Given this list of marker genes HPCAL4, TAGAP, DUSP1 (dual specificity phosphatase 1), PEAK1, PAQR5, SORT1, SPEN, RSL24D1, EEF1E1, RYBP, WLS, SBF2, ROGDI, DRG2, BLTP3B, CD68, RRP1B, FNIP1, SERTAD1, HEATR1, ATP23, POLR1B, DNMT3B, KPNA1, MIR543, SCMH1, POLR3E, CPNE4, UTP25 (UTP25 small subunit processome component), KCNF1, TLR7, PTGS2, IFT80, SLC25A29, TIMM10, SLC37A1, CRY2, IL9 (NCBI Gene Id 3578), NR4A2, SLC2A1, THEMIS2, TRPC6, BOLA1, ARHGEF10, SET, ATG4C, CLIC4, VPS33B, TNFRSF18, CD6, CAGE1, PFKL, GBP6, LYN, PAX6 (NCBI Gene Id 5080), CNKSR3, FOXP1, CD274, FXR2, IMPDH1, NUDC, GPATCH4, GRPEL2, GRK3, RAB38, GEMIN5 (NCBI Gene Id 25929), IPO4, GRPEL1, NMD3, AMER1, HYOU1, SLC25A22, HSF1, C1orf35, RBIS, A1CF, RSPRY1, EIF5B, GTPBP6, TRIO, TMEM39A, CZIB, SND1, BLNK, DOCK4, ZC3HC1, UTP20, MRTO4, IARS1, IPCEF1, FLVCR1, LILRB3, NSMCE1, CEACAM1, MTRES1, ISG20L2, CDKN1A, XPO7, CSTF1, MIR376C, TRIM42, TRIM69, SOCS5, MGA, EIF1, KANSL2, KDM5B, NHP2, MRPL38, CXXC1, SMIM12, PPAN, AXIN1, NCF1 (NCBI Gene Id 653844), SOCS1, NIPSNAP3A, ADAMTS5, MERTK, HK2 (hexokinase 2), SLC26A6, MTHFD1L, BTG2, ADORA2B, CST3, MMP25, POR, DUSP23, PSAP, NKRF, MIR17HG, ENO2, BST1, MAGEE1, DUSP10, AGO1, ANXA4, TMEM248, POLE4, SURF2, FRK, PLK3, GAA (NCBI Gene Id 2548), HIC2, U2AF2, NOP58, RANGAP1, C1orf105, CLPP, CLK4, WBP11, ITM2A, PCYT2, MFN2, RPL22, EIF4G3 (eukaryotic translation initiation factor 4 gamma 3), TAT (NCBI Gene Id 6898), SYNGR2, NOTCH2, PRR19, MRPL28, TBL3, PPP2R3A, CDC42BPA, ABCA1, AIG1, CACTIN, CHD1, SLC35C2, AGK, WFS1, AGO2, TAF4B, DCUN1D4 (NCBI Gene Id 23142), FMNL3, here is a description of the gene set: This array analysis is to study developmental time course of the regulation of target messages’ expression during culture of murine neutrophils versus miR-223 null neutrophils. Culture media was SILAC-IMDM for MS analysis. Genes up-regulated in of bone marrow progenitors: 4- versus 8-day cultures. species: Homo sapiens Human Gene Set: GSE12003_4D_VS_8D_CULTURE_BM_PROGENITOR_UP from publication Baek D, Villén J, Shin C, Camargo FD, Gygi SP, Bartel DP (PMID 18668037)